The following is a description of a gene set: Human Gene Set: GOBP_REGULATION_OF_FOCAL_ADHESION_DISASSEMBLY studied in species Homo sapiens Any process that modulates the frequency, rate or extent of disaggregation of a focal adhesion into its constituent components., and this is the list of marker genes: MAPRE2, DUSP3 (NCBI Gene Id 284066), PIK3R1, IQSEC1, ARF6, MAP4K4